The following is a description of a gene set: species: Homo sapiens Human Gene Set: WP_FATTY_ACID_OMEGAOXIDATION Fatty acid omega-oxidation, and this is the list of marker genes: CYP1A2, ALDH2, ADH4, ADH6, CYP2A6, CYP2D6, ADH1C, ADH1A, CYP4A11, ADH7, CYP1A1, CYP2E1 (cytochrome P450 family 2 subfamily E member 1), CYP3A4, ADH1B, ALDH1A1